The following is a description of a gene set: species: Mus musculus The regulated release of thyroid-stimulating hormone, a peptide hormone that stimulates the activity of the thyroid gland, from secretory granules in the anterior pituitary. Mouse Gene Set: GOBP_THYROID_STIMULATING_HORMONE_SECRETION, and this is the list of marker genes: Pax8, Dio2, Slc16a2, Slc16a10, Sirt1